Given this list of marker genes Cyp4f15, Cyp4f14, Cyp2u1, Cyp4a12a, Cyp4f40, Ahr, Cyp4f13, Cyp4a12b, here is a description of the gene set: Mouse Gene Set: GOBP_OMEGA_HYDROXYLASE_P450_PATHWAY The chemical reactions and pathways by which arachidonic acid is converted to other compounds initially by omega-hydroxylation. studied in species Mus musculus